The following is a description of a gene set: from publication Toker A, Engelbert D, Garg G, Polansky JK, Floess S, Miyao T, Baron U, Düber S, Geffers R, Giehr P, Schallenberg S, Kretschmer K, Olek S, Walter J, Weiss S, Hori S, Hamann A, Huehn J (PMID 23420886) We investigated at which stage of maturation commitment to a stable Foxp3-expressing phenotype takes place. We assessed stability of Foxp3 expression in thymic Foxp3+ Treg subsets of different maturity, defined by CD24 expression. Next we compared gene expression profiles of Foxp3+ Treg subsets (+) of different maturity (24lo, 24int, 24hi) and could identify a set of genes that were specifically up or downregulated in Foxp3+ Tregs, but not in Foxp3- conventional T cells, in a maturation-dependent manner. Human Gene Set: GSE42021_CD24INT_VS_CD24LOW_TREG_THYMUS_DN Genes down-regulated in thymic T reg: CD24 int versus CD24 low. studied in species Homo sapiens, and this is the list of marker genes: TNFSF10, GREM2, PSEN2, EHD4, IFI6, STAT2, SP100, MX1, UNKL (NCBI Gene Id 65259), TENT5A, PILRB, FAM13A, PTS, HERC6, CRELD1, KCNJ9, NPPB, GPR18, IFI44L, PDK1, TRIM21, PDGFRL, LGALS9, ROBO4, NFE2L3, GPM6A, USP18, DDX19A, ISG20, SP110, OAS1, IRF7, PMP22, MGA, HSD17B7, CMTR1, NFKBIB, UBA7, CDS2, PPL, IFI16, KMT2D, SERPINA2, EFL1, ASTE1, HLA-F, CHD4, RHBDD3, SPTLC3, RLN1, DOP1A, OR1G1, FSCN2, POU4F1, TRIM38, SLC25A28, DDX60 (DExD/H-box helicase 60), BST2, FBLN5, PHF11, IL1RAP, YPEL1, PCDHA2, OAS2, IFIH1, HERC5, IFITM2, TREX1, SYNGR3, RSAD2, DGCR5, GPR87, FOXA1, NREP, ZFHX2, EFNA3, CXCL11, TDRD7, PRKD2, RUBCNL, TRANK1, HERC2P3, NFKBIA, LIMA1, EXT1, GPR6, FADD, P4HA1, CREM, OAS3, CFLAR, NPIPA1, CLC, TRIM14, APOBEC3B, ST7, DNAJB4 (DnaJ heat shock protein family (Hsp40) member B4), TBKBP1, TMCC1, SERPINB7, BEGAIN, NEIL1, SAMD9 (sterile alpha motif domain containing 9), THBS1, SELENOP, PLSCR1 (phospholipid scramblase 1), PLSCR2, PYY, PML, LAMC3, ADAR, TRIM5, TSGA10, CDK18, XAF1, ABCC5, SERPING1, TBL2, CFAP44, MX2, DNAJC8, LAT2, S100A1, KCNA4, LARGE1, DIXDC1, OASL, FAS, RABAC1, EGF, RTP4, SH2D3C, DSP, LRTM1, BCL11B, CRABP1, NPHP4, IFITM3, NPPC, POLR2F, TM4SF1, COIL, ISG15, LAMP3, C8B, LY6E (lymphocyte antigen 6 family member E), MYD88, ATAD5, LGMN, MMP8 (NCBI Gene Id 4317), IFIT3, IFIT2, NKTR, CDH1, IFI27, ZNF362, FST, GPKOW, PARP12, FCER1A, PCSK7, ZBTB7C, TAT, SLC15A3, GPT, COL18A1, AQP3, IFI44, IFITM1, RGS2, CFB, CCL5, MACROD1 (NCBI Gene Id 28992), IL22RA1, DHCR7, MALT1, CXCL10, IFIT1, LAP3, VCPKMT, CTNNBL1, PRAME (NCBI Gene Id 4136), PLAAT2, AKR1C4, WDCP, TRIM22, SLCO2B1, H2BC13, L1CAM, LRRTM4, CHMP5, CD2, GOLGA8A, TNNT3, IFIT5, RIGI